Given this list of marker genes ALPL, BCOR, ODAPH, ITGB6, FAM20C, TFAP2A, CFTR, COL1A1, TCIRG1, WNT6, FAM20A, ENAM, ANKH, TGFB1, DMP1, AMELX, SLC24A4, HACD1 (3-hydroxyacyl-CoA dehydratase 1), ASPN, NECTIN1, FGFR1, CNNM4, STIM1, MSX2, TSPEAR, MMP20, PPARA, AMTN, AMELY, ROGDI, SLC4A2, TBX1, SP7, WLS, here is a description of the gene set: species: Homo sapiens The process in which calcium salts are deposited into calcareous tooth structures such as dental enamel, dentin and cementum. Human Gene Set: GOBP_TOOTH_MINERALIZATION